The following is a description of a gene set: Genes up-regulated in regulatory T cell (Treg) versus conventional T cells. Human Gene Set: GSE13306_TREG_VS_TCONV_UP from publication Hill JA, Hall JA, Sun CM, Cai Q, Ghyselinck N, Chambon P, Belkaid Y, Mathis D, Benoist C (PMID 19006694) studied in species Homo sapiens CD4(+)Foxp3(+) regulatory T (Treg) cells originate primarily from thymic differentiation, but conversion of mature T lymphocytes to Foxp3 positivity can be elicited by several means, including in vitro activation in the presence of TGF-beta. Retinoic acid (RA) increases TGF-beta-induced expression of Foxp3, through unknown molecular mechanisms. We showed here that, rather than enhancing TGF-beta signaling directly in naive CD4(+) T cells, RA negatively regulated an accompanying population of CD4(+) T cells with a CD44(hi) memory and effector phenotype. These memory cells actively inhibited the TGF-beta-induced conversion of naive CD4(+) T cells through the synthesis of a set of cytokines (IL-4, IL-21, IFN-gamma) whose expression was coordinately curtailed by RA. This indirect effect was evident in vivo and required the expression of the RA receptor alpha. Thus, cytokine-producing CD44(hi) cells actively restrain TGF-beta-mediated Foxp3 expression in naive T cells, and this balance can be shifted or fine-tuned by RA., and this is the list of marker genes: SP7, GTF3C2, KITLG, CCDC57, TRPM1, CABP7, CDK18, ARF4, IGF1, TLR1, SNX31, LRRC61, FAM167A, CELSR2, TNFRSF12A, ATP10D, SPINK2, GABRG2, RTEL1, IZUMO1R (NCBI Gene Id 390243), CHD8, FXYD1, SAMD4A, OPRL1, MYO6, HSF2BP, TECTB, INPP5A, ZC3H12D (zinc finger CCCH-type containing 12D), TMEM202, SECTM1, PRMT8, SYT17, CACNA2D4, BCL9L, BMS1, ISG20, SCNN1G, ICOS, DNAJB13, CASP12, GSTM2, USH2A, SMPD3, TIMP1, PSPN, SORCS2, NLRP6, SPMIP4 (NCBI Gene Id 136895), PER3, CCND2, DELE1, SH3PXD2A, AK5, EVC2, ASCL2, ABHD6, FGGY, CSF1, DOCK7, TAGLN, THSD7B, SLC4A5, CATSPER1, RESF1, PLEKHA6, RAPGEF6 (Rap guanine nucleotide exchange factor 6), SLC45A2, PEX11A, ADCY1, ZNF462, MGME1, LYRM7, DLG3, ADAMTSL2, CSRNP1, VAMP1, PHLDA1, NFIX, CDX2, RUSC2, RITA1, CTSV, C7orf50 (NCBI Gene Id 84310), NFKBIA, CLDN15, RGS20, TMEM132A, DDIT4, IL7, DUSP1, KAT2B, LTF, RNASE10, FRMD6, ASXL1 (NCBI Gene Id 23393), ASTN2, LRIG1, LTB, RAD54L2, CDKN1C, PLA2G4E, ADCY5, TGFBRAP1 (NCBI Gene Id 9392), R3HCC1L, GJB4, CUL4A, TEKT2, ALDH5A1, BMP8B, ZDHHC23, STX6, DOCK1, TMEM217, NUPR1, TEF, ARL3, EVI5L, ZBTB39, S100A13, TTYH2, MYO16, ARSG, ACOT7, SCRN3, EMILIN3, HBB, PECAM1, GABARAP, SYPL2, TSC22D1, BLNK, TRMT12, THBS1, RAB11FIP2 (NCBI Gene Id 22841), MED18, BHLHE23, C1QTNF9, SMC4, BAG5, RAMP1, TFEC, KANSL1L, PPDPF, ICMT, ARHGEF25, MS4A13, NPY5R (NCBI Gene Id 4889), PARK7, DCST1, DRC1, CD2AP, APOBEC1, PPP1R14C, TMEM45A, MTCL2, CRB3, PRDM5, B3GALT5, ADPGK, MYOC, ZSCAN29, CACNA1B, MAPKAPK3, HSPBAP1, CELF4, TRPC3, CCR4 (NCBI Gene Id 1233), ZNF575, GFRA3, ADAMTS18, NPR2, C3orf18, AFG1L, CHRNA6, NET1 (neuroepithelial cell transforming 1), KCNQ2, MRGPRF, ZNF608, MAPK15, UPK2, TMEM51, CAMKK1, ALDH8A1 (NCBI Gene Id 64577), SGSM1, MAP3K21, TDRD7, VAMP3, TENT5A, SERPING1, CNTFR, SOD1, HMGB4, YPEL2, EPB41L1, ARHGEF28, RCOR2, TAS2R1